Given this list of marker genes HVCN1, CYBB, CLEC2D, NDRG2, FCMR, MYB, SH3BGRL3, PDE7B, ARRDC2, PDE3B, LINC00921, CD4, UTRN, TXNIP, ACP5, PDK4, STK26, ID3, SFXN3, GCNT4, MREG, ITGB2 (NCBI Gene Id 3689), UEVLD, SMC4 (NCBI Gene Id 10593), SLC38A6, CCDC88A, GABBR1, NMT2, ALDH1A1, LAIR1, C1orf162, IL17RA (interleukin 17 receptor A), YPEL4, CTSS, MANBA, PARP4, CD52, GPC4, CSF3R, TTYH2, CYBRD1, DYNLT3, RSPH3, RCBTB2, TIMP2, APBB1IP, DGKD, RCSD1, NFAM1, G6PD, SNRK, CD109, ABHD4, MINDY1, RGCC (regulator of cell cycle), GPAT3, TBL1X, TMT1A, RAB37, UBXN11, RTN1, ELF1, PRDM8, MYO1E, NCKAP1L, PNMA8A, HGSNAT, ATP6AP1, CD180, JAML, CD40LG, CD36, DPYSL2, STAB1, MARCHF1, ADCY7, CRIM1, MITF, DPEP2, NFE2L2, TMEM144, CREBL2, PDE7A, CLDN12, AHNAK, CORO6 (NCBI Gene Id 84940), FIG4, RNASE6, PYGL, SIRPG, TNFAIP2, TOB1, CD96, H2AJ, DHRS9, ATP6AP2, CD9, SLC16A5, SLC9A6, SPARC, TSPAN33, DNAAF4, GGTA1, ANKRD44, MAP7D1, ABI2, NCAM1, TIMD4, NLRP3, RAP2B, RRM1, GSN, TMBIM1, ECM1 (NCBI Gene Id 1893), AQP3, CREG1, CSGALNACT2, GM2A, TBXAS1, IRAG2, IL13RA1, ADA2, ME1, PPFIBP1, SORBS3, ATL1, ERMAP, FMNL1, CSF1R, IL36A, CALCOCO1, CALHM2, VPS45, FGL2, DIAPH1, C5, STAT4, GSTO1, TNFRSF1A, RNASE1, KLF3-AS1, LRP1, PIP4P2, HLA-DMB (major histocompatibility complex, class II, DM beta), LGALS3, SLC8A1 (NCBI Gene Id 6546), TGFBI, ARRDC3, ANTXR2, HAAO, EVI2B, CD3G, CD27, ARRB2, ADGRE5, PLBD1, KLHL3, ZYX, CLEC4E, TRAV8-3, DECR1, IGFLR1, PSAP, GASK1B, ACAP2, AK5, SLCO3A1, CEMIP2, SSBP2, IL23A, HDAC5, FYN, RAB8B, TMEM63A, TLR6 (NCBI Gene Id 10333), TPP1, RRM2B, NRCAM, TNFAIP8L2, SMIM14, JOSD1, PELI1, PLXDC1, PLD3, LBH, FLNA, EVI2A, SLC44A1, RASGRP2, TNFAIP3, PRCP, VSIR, SDCBP, PTPRJ, LYZ, ABCC3, CCDC65, SPPL2A, FAM111A, ADAM28, here is a description of the gene set: Genes up-regulated in CD4 T cells with STAT3 knockout: medium versus IL6. from publication Durant L, Watford WT, Ramos HL, Laurence A, Vahedi G, Wei L, Takahashi H, Sun HW, Kanno Y, Powrie F, O'Shea JJ (PMID 20493732) Human Gene Set: GSE21670_UNTREATED_VS_IL6_TREATED_STAT3_KO_CD4_TCELL_UP studied in species Homo sapiens STAT3, an essential transcription factor with pleiotropic functions, plays critical roles in the pathogenesis of autoimmunity. Despite recent data linking STAT3 with inflammatory bowel disease, exactly how it contributes to chronic intestinal inflammation is not known. Using a T cell transfer model of colitis we found that STAT3 expression in T cells was essential for the induction of both colitis and systemic inflammation. STAT3 was critical in modulating the balance of T helper 17 (Th17) and regulatory T (Treg) cells, as well as in promoting CD4+ T cell proliferation. We used chromatin immunoprecipitation and massive parallel sequencing (ChIP-Seq) to define the genome-wide targets of STAT3 in CD4+ T cells. We found that STAT3 bound to multiple genes involved in Th17 cell differentiation, cell activation, proliferation and survival, regulating both expression and epigenetic modifications. Thus, STAT3 orchestrates multiple critical aspects of T cell function in inflammation and homeostasis.